Given this list of marker genes SLC9A1, SLC9A7, SLC9A3, SLC9A2, SLC9A5, SLC9A6, SLC9A8, SLC9A9, SLC9A4, here is a description of the gene set: Sodium/Proton exchangers species: Homo sapiens Human Gene Set: REACTOME_SODIUM_PROTON_EXCHANGERS